The following is a description of a gene set: species: Homo sapiens Human Gene Set: GOBP_GALACTOSE_METABOLIC_PROCESS The chemical reactions and pathways involving galactose, the aldohexose galacto-hexose. D-galactose is widely distributed in combined form in plants, animals and microorganisms as a constituent of oligo- and polysaccharides; it also occurs in galactolipids and as its glucoside in lactose and melibiose., and this is the list of marker genes: GLB1L, GALE, CHST1, GLB1L2, GALM, SLC35A2, GLB1L3, PGM1, B4GALT1, GALT, GALK2, GALK1, GLB1